The following is a description of a gene set: Genes up-regulated in thymic T reg: CD24 int versus CD24 low. We investigated at which stage of maturation commitment to a stable Foxp3-expressing phenotype takes place. We assessed stability of Foxp3 expression in thymic Foxp3+ Treg subsets of different maturity, defined by CD24 expression. Next we compared gene expression profiles of Foxp3+ Treg subsets (+) of different maturity (24lo, 24int, 24hi) and could identify a set of genes that were specifically up or downregulated in Foxp3+ Tregs, but not in Foxp3- conventional T cells, in a maturation-dependent manner. studied in species Homo sapiens Human Gene Set: GSE42021_CD24INT_VS_CD24LOW_TREG_THYMUS_UP from publication Toker A, Engelbert D, Garg G, Polansky JK, Floess S, Miyao T, Baron U, Düber S, Geffers R, Giehr P, Schallenberg S, Kretschmer K, Olek S, Walter J, Weiss S, Hori S, Hamann A, Huehn J (PMID 23420886), and this is the list of marker genes: LAGE3, MAGI2, TCEAL1, LINC00667, IRF3, PTH, MLF1, SLC4A7, PRRC1, CTRC, H2AC14, SERPINB10, CENPC, IKZF3, NAA80, FAM168B, AMZ2, CCR5, NEFM, C3AR1, SLC17A9, SERINC5, KRT12, OCM2, MRPL48, NUDT9, MAN2B1, NAIP (NLR family apoptosis inhibitory protein), CPSF1, GCG, SIPA1L3, LMO1, PRKACA, TRPS1, LRRFIP2, MKNK2, ZNF287, ITGAE, ADAMTS5, EEF1AKMT2, ST13, SMUG1, HTR7, TMPRSS4, OPCML, IFNA5, GPC5, OR7E156P, MLXIPL, IL1R2, AHSP, FHOD3, LANCL2, AP1S2, GFM1, SAYSD1, ITIH3, SCYL2 (SCY1 like pseudokinase 2), ZNF215, LAPTM5, TBC1D5, RNF39, NEK11, RFX1, DMC1, ADAM3A, PLAAT1, GPN1, IMPDH2, EIF3L, RASAL2, CDC42, TMCO3, DDX39A, VPS45, TP53BP2, ACTR2, ITGAV, HPD, ST8SIA2, PIGQ, PLOD3, EEF2, DXO, IL37, LRRC17, POM121, CCNC, SAGE1, PIERCE1, COL9A3, IMPG1, IGFALS, GPX4, DNAH17, PRKAR2A, IGLL3P, PLS3, CYP17A1 (cytochrome P450 family 17 subfamily A member 1), SLCO1A2, PSENEN, TOP6BL, ASCL2, IZUMO4, CD83, FGL2, EIF2D, RAD17, TOM1L2, ADD2, CD1D, C1orf105, PGF, CLK3, RGL1, VPS16, COPZ1, AVEN, USP22, RBM3, ASCC3, PTGDR, LTA4H, NEBL, BCAT1, DNAJC3 (DnaJ heat shock protein family (Hsp40) member C3), ERLIN1, PLA2G2F, TACSTD2, C1orf21, WSCD1, STK11, TRMT112, IDE, MARK3, MMP16, LRCH4, TMEM40, SPAST, GSTA3, PKD2L2, SNTG1, TMEM100, LIMS1, ZKSCAN5, TSHR, NOX3, RPL18, MARF1, IPO4, REXO5, ALCAM, MUC4, ACO1, DYRK2, ULBP1, CALB2, ERMAP, ITK, IPO5 (NCBI Gene Id 3843), DCAF1, GNPAT, APBA1, COTL1 (NCBI Gene Id 90755), THAP4, EIF3J, GPSM2, MAP9, IREB2, GAS7, ONECUT1, CBX5, SULT1C2, CORO1A, ESM1, ASAP2, BRD9, F13A1, VARS1, BLTP2, MAP1A, RRAS2 (RAS related 2), CCDC22, SLC7A11, MPZL2, TDRD3, CEBPA-DT, PIP4K2B, RFXAP, ANKS1B, HEBP1, ZNF667, IRF8, CDC42BPA, IL10RA, MAT1A, ARL6IP4